The following is a description of a gene set: Production of bile by the liver is crucial for the absorption of lipophilic nutrients. Dysregulation of bile acid homeostasis can lead to cholestatic liver disease and endoplasmic reticulum (ER) stress. We show by global location analysis ('ChIP-on-chip') and cell type-specific gene ablation that the winged helix transcription factor Foxa2 is required for normal bile acid homeostasis. As suggested by the location analysis, deletion of Foxa2 in hepatocytes in mice using the Cre-lox system leads to decreased transcription of genes encoding bile acid transporters on both the basolateral and canalicular membranes, resulting in intrahepatic cholestasis. Foxa2-deficient mice are strikingly sensitive to a diet containing cholic acid, which results in toxic accumulation of hepatic bile salts, ER stress and liver injury. In addition, we show that expression of FOXA2 is markedly decreased in liver samples from individuals with different cholestatic syndromes, suggesting that reduced FOXA2 abundance could exacerbate the injury. Human Gene Set: BOCHKIS_FOXA2_TARGETS from publication Bochkis IM, Rubins NE, White P, Furth EE, Friedman JR, Kaestner KH (PMID 18660816) species: Mus musculus Direct targets of FOXA2 in liver, according to a ChIP-chip analysis., and this is the list of marker genes: IL6, SLC13A2, FMO2, BMI1, INSIG2, COL11A1, FHIP2A, PBLD, ATP5PF, FDFT1, PLD2, MINDY2, KCTD20, MCM4, VDR, TSEN15, SERPINF2, EIF1AY, NR0B2 (NCBI Gene Id 8431), HBS1L, PROS1, DAD1 (NCBI Gene Id 1603), RAB43, CHAC2, ARRDC4, EMC9, GABPA, MIA2, KBTBD12, SLC6A12, MRPL36, CEBPZ, DHRS1, RAPSN, PLG, GCAT, KLK11, KIF9, TRPM8, RPL21, PER1, PLEKHA6, GAST, C1RL, C6, SERPINA1, SMIM3, PDE6D, IL11RA, STARD13, RBBP5, APOH, GASK1A, GDE1, SIN3A, ALDH1A1, DHCR7, PLEKHG3 (pleckstrin homology and RhoGEF domain containing G3, NCBI Gene Id 26030), GRAMD2B, PIGR, CYP2E1, BAAT, LHX1, KBTBD2, COCH, FTL, SEPHS2, CAT, TCP11L2, TJP2, KLHL18, RHOD, NDUFA2, INSC, AMBP, UOX, NR1I2 (NCBI Gene Id 8856), GHITM, EBAG9, TST, MAFG, LRP1, CYP4F2, ZC3H8, RITA1, PPP4R3B (protein phosphatase 4 regulatory subunit 3B), PCLAF, MRPS2, ZNF3, HAVCR1, AASS, CLP1, TC2N, SERPINC1, GSTM1, FMO3, GLCCI1 (NCBI Gene Id 113263), SERPINA11, ACSL1, RPL39L, SH3D19, PZP, CRKL, PDK4, AKT1, HPS1, TMEM140, AACS, DHX38, PLRG1, COQ8A, SLC39A5, VARS1, TMEM121B, ALKBH6, TBC1D15, PIK3AP1, F13B (NCBI Gene Id 2165), TBL1XR1, TXNL4B, CD47, MBL2, PFDN2, C4BPA, CYB5A, ESRP2, PRDX1, PRCC, TMEM259, ECT2, LEAP2, ABCA1, TEDC2, CD300LF, GFUS, PRMT5, RAB3B, LIPC, CLCN7, UFD1, FOXP2, AP3M1, LYN, IDH2, DNASE2B, SORT1, KLF15, FAAH (NCBI Gene Id 2166), PCK1, SPZ1, CYP2A6, AQP8, ZMYM1, CES1, RDX, CD82 (CD82 molecule), DRAM2, PSME1, PSMB10, FBXO4, TK1, CHMP5 (NCBI Gene Id 51612), PRDX6, ITM2B, IDH1, ZNF235, NKX2-5, HIVEP1, COPG1, OIT3, MTX2, SCARB1, INSIG1, APOA5, CYP2J2, COL10A1, AP3S1, COL2A1, CYP2D6, RETN, ZSWIM4, TUSC2, DEPP1, AP4M1, UGT2B4, CLN8 (CLN8 transmembrane ER and ERGIC protein), NUP43, ZDHHC17, NRROS, HACD3, FBP1, GIMAP5, IGFBP1, CFI, PON2, SLC25A14 (NCBI Gene Id 9016), DDX3X, TMEM87A, NDUFS8, BTBD3, ZBTB5, TFAP4, WDR46, DMTF1, SLC25A10, MOB2, GABARAPL1, SYS1, CTNNBIP1, NDUFA8, TEX261, ID3, RIBC1, AHSG, CTH, EVC2, HM13, PANX1, SCRN3, FAH, NEK8, SLC25A42, SLC31A1, H2AC8, RENBP, C9orf152, EOLA1, DHRS7, CYP7B1, HABP2, NDRG2, ALDOB, PEMT, GDPD1, FEM1A, LIFR, CYP2C19, SLC25A25, DPM1, STAT2, EEF1B2, HADHA, FOXA2, HMGB2, TTR, PLA2G6, F2RL2, RDH16, HAO1, CHD1, MXD1, SERPINA6, ARHGAP23, APOC1, EFNA1, PRXL2C, TERF2, LDLR, SERPINA3, BCDIN3D, APOE, OMD, PIGO, GPRC5C, BANF1, VPS26B, DCAF13, HERC4, GATA3, KNG1, PHF10, HPX, ATF4, OR10K2, GPAM, PPARG, SAA4, PTCD2, AMFR, CHUK, MERTK, HACL1, FAM43A, ACSM3, GNL3, POLR2C, ISG15, ZNF880, FAM107B, FGL2, APONP, SLC17A2, ACAA1, DCAF11, PRKDC, LRRC41 (leucine rich repeat containing 41), PTK2, TRAP1, BCAS3, SLC25A47, CABCOCO1, HSPA1L, RNF4, H2AJ, KATNB1, CDC42EP4, AHCY, LRG1, STX19, TPST2, MKKS, NRIP1, CLEC4A, NAT8, PCGF5, MLXIPL, SELENOO, BRCA1, CREBL2, EIF4A2, PA2G4, PRKAR2A, ITPR1, DPH7 (NCBI Gene Id 92715), SON, MAFK, ARHGAP12, AKTIP, C19orf12, DHX8, LRPPRC, C8B, KDM6B, TRIM13, CYP2C8, GANAB, TIAL1, ITPKC, SORD, CALD1 (NCBI Gene Id 800), CNR2, UBL3, GK, MPZL2, TARS1, TP53BP2, LRRK1, CRYL1, RASSF6, CBLL1, F7, CS, ZBTB17, CXCR4, OSER1, MAL2, GPR35, TIMM9, HAGH, NECAB1, UROC1, SQOR, COLEC12, NUF2, GAS1, APP, CYP17A1, ITIH1, SLC46A3, IGFBP4, BNIP3, EXPH5, COA4, TNFRSF1A, DNAJB11, JUNB, CD276 (NCBI Gene Id 80381), PLIN2, FIGNL1, TTC7A (tetratricopeptide repeat domain 7A), NEPNP, CDH2, ZKSCAN5, PSEN2, AK3, CISH, GPT, QSOX1, C1R, MAT1A, FGB, CCR8, ATG12, ZNF395, CHGA, SLC37A4 (solute carrier family 37 member 4), HPGD (NCBI Gene Id 3248), UBE2L6, NFU1, MAPKBP1, PES1, CD9, CDK5, NQO2, PHF20, ABHD8, THPO, MT1X, ZSCAN12, PPARA, OSBPL1A, KLKB1, AFMID, GYS1, PI4K2A, INHBE, POT1, PER2, HGD, PPM1B, CLEC2D, ODAD3, STARD5, ALDH6A1, SAR1B, PSMG3, KLF3, PLOD2, DDX19A, PNPLA2, IL6ST